The following is a description of a gene set: studied in species Homo sapiens Human Gene Set: MIR629_5P from publication Chen Y, Wang X (PMID 31504780) Genes predicted to be targets of miRBase v22 microRNA hsa-miR-629-5p in miRDB v6.0 with MirTarget v4 prediction scores > 80 (high confidence targets)., and this is the list of marker genes: TEAD4 (TEA domain transcription factor 4), TSHZ1, CEP350, GPR83, MMP16, HUS1, CCR1, GAB1, ATCAY, CEP55, RTN4RL1, KRT40, ANO5, ANGPTL7, TCAF1, TLK2, HSPB2, RBFOX1, ESPL1, GPR6, TMEM106B, ASPH, MARCHF6, COL4A5, TRIM33, ZBTB1, SFT2D1, ESRRG, UBE2E3, PHYH, CDC37L1, ZNF831, ZFP3, ALAD, RRP15, KLHL13, KRT32, PIN1, RHNO1, RNPS1, SLC25A3, EPC1 (enhancer of polycomb homolog 1), WDR47, NAP1L5, YTHDF2, PSMA2, SNX30, MAML2 (mastermind like transcriptional coactivator 2), PDE7A, ZNF214, MIEF2 (NCBI Gene Id 140774), KCNK2, SARAF, PPBP, KIAA0753, CDH6, CLDN8, CIDEA, BMP2K, CHRNA9, SNX18, GAL3ST1, MTRF1L, AGA, MED13L, DESI2, HS3ST3A1, EIF2A, VDAC3, HNF4A, TCF4, SPATA31D3, FZD3, ELAVL4, GNRHR, PRLR, RASSF8, ADAM12 (ADAM metallopeptidase domain 12), FAF2, HDHD2, CBLL1, TRIL, MAPK10, TMEM9B, GPATCH2L, TNRC6C, NAV1, ZRANB2, DENND5B, ANGPTL3, NFX1, LRP6, NID1, ATG5, PKLR, EIF1AD, SPRY3, SFRP2, RFX4, YY1, PRRG1, FRZB, EFR3B (EFR3 homolog B), CDH11, INSYN2B, CEP250, MUC3A, UBR3, YPEL5